Given this list of marker genes TRIM38, PDE12, APOBEC3H, CLEC4G, LARP7, IFITM1, CD28, VAPB, HMGB1 (high mobility group box 1), APOBEC3G, ATG5, IFIT1, CSNK2B, SHFL, BST2, PPIA, IFIH1, APOBEC3F, CCL5, DYNLT1, SP100, BTBD17, RSF1, FKBP6, TARBP2, PLSCR1, ZC3HAV1, CNOT7, SRPK2, DDX3X, DHX9, VPS37B, LARP1, TRIM13, APOBEC3A, RSAD2, TNIP1, OAS3, BSG, TOP2A, LGALS9, DDB1, BANF1, TYRO3, TRIM27 (NCBI Gene Id 5987), TMEM39A, NECTIN2, UBP1, ADAR, ISG15, IFITM3 (NCBI Gene Id 10410), TRIM31, TMPRSS4, RNASEL, MBL2, SMPD1, ZNFX1, LGALS1, FAM111A, OASL, PROX1, AXL, APOBEC3C, IFIT5, STOM, IFITM2, CD4, RAD23A, VPS4A, PPIH, TRIM8, AICDA, NOTCH1, EIF2AK2, IFI16, KPNA2, TSG101, LAMP3, SLPI, OAS2, CD74, TRIM6, HS3ST5, IFNL3, HMGA2, TRIM25, PPIE, ISG20, PTX3, CD209, TMPRSS2, STAT1, ZFP36, BCL2, ATG12, PKN2, APCS, IFNB1, MAVS, MID2, APOBEC3D, FURIN, APOBEC3B, LTF, IL32, HACD3, MDFIC, HEXIM1, ADARB1, ILF3, ARK2N, TRIM21, P4HB, PPID, CXCL8, TBC1D20, KPNA6, TOP2B, TRIM5, TMEM250, OAS1, SRPK1, RAB7A, TNF, DDX5, TRIM11, PABPC1, TRIM15, N4BP1, INPP5K, HLA-DRB1, TRIM32, GBP7, CH25H, MX1, FMR1, TRIM28, STAU1, TRIM14, NR5A2, TRIM62, here is a description of the gene set: studied in species Homo sapiens Human Gene Set: GOBP_REGULATION_OF_VIRAL_PROCESS Any process that modulates the rate or extent of the viral life cycle, the set of processes by which a virus reproduces and spreads among hosts.